Given this list of marker genes Srpk2, Clns1a, Cers6, Mapk8, Uvssa, Zfp131, Clec10a, Rps6kb1, Actr2, Adhfe1, Prob1, Slc26a1, Zic3, Ensa, Ube2d1, Adgrv1, Cacna2d2, Fam98a, Elovl5, Ctf1, Ppp2r5c, Gphn, Svip, Prss16, Rimoc1, Aff4, Drp2, Cnot6l, Kras, Zfp119a (zinc finger protein 119a), Gzf1, Chi3l1, Abcf3, Mtss1, Ptbp2, Mark3, Pcdh9, Bptf, Ramac, here is a description of the gene set: species: Mus musculus Genes predicted to be targets of miRBase v22 microRNA mmu_miR_24_1_5p, mmu_miR_24_2_5p in miRDB v6.0 with MirTarget v4 prediction scores > 80 (high confidence targets). from publication Chen Y, Wang X (PMID 31504780) Mouse Gene Set: MIR_24_1_5P_MIR_24_2_5P